The following is a description of a gene set: Genes up-regulated at the peak of an antigen response of naive CD8+ T-cells. studied in species Mus musculus Human Gene Set: GOLDRATH_ANTIGEN_RESPONSE from publication Goldrath AW, Luckey CJ, Park R, Benoist C, Mathis D (PMID 15548615) Naive T cells proliferate independently of cognate antigen when introduced into lymphopenic hosts. Lymphopenia-induced proliferation depends on low-affinity MHC/self-peptide complexes and on IL-7. To elucidate the intracellular signals mediating this proliferation, we analyzed changes in gene expression in naive CD8+ T cells at different times after their transfer into a lymphopenic environment. The genes induced in response to lymphopenia were largely an attenuated subset of those turned up by full antigenic stimulation, including genes related to cell cycling, whereas excluding genes specifically associated with effector activity. After the initial phase of proliferation in an empty compartment, the naive T cells adopted a stable pattern of gene expression similar to that of antigen-experienced memory cells. Thus, T cells proliferating in lymphopenic hosts do not exhibit a unique gene-expression profile, instead relying on traditional signals for this antigen-independent proliferation; this process ultimately results in differentiation to authentic memory cells., and this is the list of marker genes: M6PR, IRF8, FASLG, KLRK1, FYN, DTL, CCL15, TMED7, RNASEH2B, GEM, HMGB2, SOCS2, SSX2IP, CDC6, IGKV5-2, CASP1, GADD45B, CDCA5, TMEM97, AURKB, FANCM, PLBD1, TMEM14C, RAD21, S100A13, ID2, CTNNA1, HOPX, ANLN, SIVA1, IFITM3, TTC39B, PLSCR1, NCAPH, CISH, C4orf3, MGST1, LMNA, CA2, ZNF207, MAPK6, HLA-B, SERPINB9, BHLHE40, N4BP1, ITSN1, DLGAP5 (DLG associated protein 5), HAT1 (histone acetyltransferase 1), PLCG2, CKS1B, TCEAL9, ARHGAP21, IGKV2D-30, MYADM, KIF4A, GSTT1, UNC119, GMNN, MXD3, ERRFI1, HBB, CCR5, GZMB, NUP62, C6orf89, ALCAM, DUSP1, HLA-DRB1, PRDX4, GNPDA1, BIRC5, MAD2L1, SNU13, RACGAP1, ODC1, TMEM30A, MTHFD2, REEP5, CXCR3, RORA, CCNB2 (NCBI Gene Id 9133), CD68, MAP2K3, YWHAQ, ABRACL, AK3, PCNA, MKI67, IGHG3, BUB1, EBP, PIM1, ELL2, TRAPPC1, TRIP13, BATF3, CHIA, HMGN2, LYN, PGAM1, MRPL18, IGSF10, RUNX2, MDFIC, GZMK, STARD10, AURKA, SLC4A1, ACOT7, CHEK1, HASPIN, PSMC3IP, F2R, MCM10, H3C1, F2RL3, CD48, H1-0 (NCBI Gene Id 3005), CCL3, RAN, GZMA, PLD4, SDHD, EMP3, CPOX, PRDM1, GNG10, SLC39A4, KIF22 (NCBI Gene Id 728037), TMPO, NEK2, TK1, SERPINB6, IFI30, TMEM126A, IL18RAP, PRF1, PLK1, SLPI, CAPG, CYFIP1, CDC20, ALAS2, CENPA, EFHD2, PRIM2, MS4A1, CDCA3, LAT2, KIF2C (NCBI Gene Id 11004), KRTCAP2, EIF1AX, KIF11, BCL2A1, S100A6, ANXA1, IGHV1-2 (NCBI Gene Id 28474), TNFRSF9, HAUS6, MCM4, YBX3, LXN, NPTN, LMNB1, PLEKHB2, CMC2, CDCA8, LAG3, IGLC6, MIS18BP1 (MIS18 binding protein 1), TPM4, RFC5, TTK, UBE2T, ITGA4, MYO1F, TACC3, ARL5A, CDKN2C, TOP2A, PERP, SCPEP1, IGHV1-24, RAB11A, KLRB1, IGHG1, JCHAIN, SERINC3, IRF4, TYROBP, TMEM37, IER3, HLA-DQB1, CHAF1A, ATP5IF1, TBL2, LIG1, CRYBG1, INCENP, MCM5, RNF227, KPNA2, DNA2, NRP1, SGCB, UBL3, IGKV4-1, CIP2A, FGL2, HPF1, DHFR, H2AZ2, CAPN2, BRCA1, AHNAK, RHOQ, SLC4A7, GCAT, NUSAP1 (NCBI Gene Id 82534), HIP1R (NCBI Gene Id 9026), RNH1, CKAP2, MT1F (metallothionein 1F), CCL4, POLA1, ITGAX, PDCD1, RRM1, ADAM8, ALAD, E2F8, NAPSA, LGALS3, CCNF, RAD51AP1, PCLAF, IQGAP3, SLC2A3, SLC31A1, ASF1B, SP100, MT1X, SKAP2, MYL4 (myosin light chain 4), CD74, ROM1, NFIL3, ITGB1, FUT7, CDK2AP1 (NCBI Gene Id 8099), VCL, TAF9, SERPINA3, CA1, CLIC4, DBI, SQLE, WEE1, SYCE2, EZH2, EEA1, ADGRE1, CMA1, SPDL1, CISD1, TXN, ANXA4 (annexin A4), H2AZ1, KIF20A, CASP3, PGLYRP1, SYPL1, S100A11, ANXA2, IFNG, IGLV2-18, GZMM, MCM3 (NCBI Gene Id 4172), C3, GGH, H2AX, CCNB1, S100A10, EVI2A, LITAF, HMBS, CDC25C, HSPA2, SH3BGRL, CD44, FIGNL1, CDC45, SLC25A53, CST3, PLP2, MAPRE2, RELL1, HLA-DQA2, CITED2, TPI1, DSTN, PRC1, TYMS, CTLA4, SLC66A3, EMP1, RRM2, CCNA2, PGM2, DHRS1, ST3GAL6, RBM3, H1-2, NCF4, PLK4, TKTL1, CCL5, CRMP1, UGT1A10, KANK3, IL2RA, CDK1, POLR3K, DENND5A, ECT2, SNX10, ASPM, STMN1 (NCBI Gene Id 3925), IGKV1-27 (immunoglobulin kappa variable 1-27), CD244, CBX5, GSTO1, PTGER4, IGLC1, IL18R1, CARHSP1, GLRX, DOCK5, SNX3, LRRC59, TCF19, CCR2, LGALS1 (NCBI Gene Id 3956), GTSE1, CDKN3, KIFC1, PRIM1, FEN1, HEMGN, CCDC50, CD24, RHD, RAD51, S100A4, KLRG1, BAG3, FHL2, LYL1 (LYL1 basic helix-loop-helix family member), NUDT4, CTSD (cathepsin D), TOPBP1, RPA3, ETFB, CKS2, IL12RB1, IGHV2-26, ITM2B, ECH1, GAPDH